The following is a description of a gene set: Human Gene Set: HP_DECREASED_CIRCULATING_TOTAL_IGG_CONCENTRATION Decreased circulating total IgG concentration studied in species Homo sapiens A reduction beneath the normal level of total immunoglobulin G (IgG) in the blood., and this is the list of marker genes: CR2, IVNS1ABP, ATP6AP1, CD81, KNSTRN, CD19, KDM6A, KMT2D, SYK, PIK3CD, MS4A1, PSMB10